The following is a description of a gene set: from publication Kondo S, Kubota S, Mukudai Y, Moritani N, Nishida T, Matsushita H, Matsumoto S, Sugahara T, Takigawa M (PMID 16247469) species: Homo sapiens Genes up-regulated in HSC-2/8 cells (chondrosarcoma) under hypoxic conditions. Connective tissue growth factor (CTGF/CCN2) can be induced by various forms of stress such as exposure to high glucose, mechanical load, or hypoxia. Here, we investigated the molecular mechanism involved in the induction of ctgf/ccn2 by hypoxia in a human chondrosarcoma cell line, HCS-2/8. Hypoxia increased the ctgf/ccn2 mRNA level by altering the 3'-untranslated region (UTR)-mediated mRNA stability without requiring de novo protein synthesis. After a series of extensive analyses, we eventually found that the cis-repressive element of 84 bases within the 3'-UTR specifically bound to a cytoplasmic/nuclear protein. By conducting a UV crosslinking assay, we found the cytoplasmic/nuclear protein to be a 35 kDa molecule that bound to the cis-element in a hypoxia-inducible manner. These results suggest that a cis-element in the 3'-UTR of ctgf/ccn2 mRNA and trans-factor counterpart(s) play an important role in the post-transcriptional regulation by determining the stability of ctgf/ccn2 mRNA. Human Gene Set: KONDO_HYPOXIA, and this is the list of marker genes: FLT3LG, IL6, CCN2, CCR2, VEGFA, TTR, IL13, TIMP1